Given this list of marker genes PRICKLE2, ZNF497, SYT13 (NCBI Gene Id 57586), ENC1, PLXNA3, C1orf21, RTN1, AMER2, LRRC49, LONRF2, AUTS2 (NCBI Gene Id 26053), AKR1C1, GPRIN1, EMX2, EPB41L1, LETMD1, RBFOX2, RNF182 (ring finger protein 182), NFASC, MAPK8, CXADR, NAP1L5, RALYL, ZBED4, ELAVL4, ELAVL2, ROBO3, ELAVL3, MCF2L, PAK3, NEDD4L, LRRTM4, GDAP1L1, SCRT2, SLC38A1, ANK3, ATCAY, MAP2, TLCD3B, GOLGA7B, KLHL35, MTUS2, TMEM132B, TBC1D2B, GABRG2, SLC8A2, SORCS3, DOCK3, GABRB3, KLHL1, BAALC, C1orf35, CACNB3, SV2A, CD2, PPFIA2, PHACTR3, CELF3, CD24, SEZ6L2, SAMD14, LHFPL4, SBK1, SMIM18, TMEM121B, CELSR3, ATP6V1H, NKAIN1, FGF14, SEPTIN3, POU2F2, KLC1, TES, SLC6A15, CERS6, GREM2, KIF3A, PTPRO, UNC79, PHYHIPL, EBF3, DCLK1, KCNH8, KCNA3, SCN3A, NREP, ADAMTS5, PCDHGC3, ANK2, RBM18, ALDH1L2, DPYSL3, ETFB, SHANK2 (SH3 and multiple ankyrin repeat domains 2), XIST, MAP6, LRFN5, GRIN3A, MARCHF1, RAB3A, CDC42EP3, DUSP4, IQCJ-SCHIP1, MAPK8IP2, UCHL1, NOL4, SLC22A15, SLC16A14, FOXA2, EPB41, USP49, VASH2, NMNAT2, FGF12, PEX5L, PAPPA, BCL11A, JPH4, DNM3, ZNF354A, ACSL6, GPC2 (NCBI Gene Id 2818), B3GALT2, PDE4DIP, ATP1A3, FBLL1, MMP24, SNCG, PHF21B, MYO5A, TRIM36, NSG2, STMN2, TAFA2, NRXN1, CNR1, GNG2, ADARB2, MLLT11, SCARA5, ARRB1, MAPK6, COMMD3-BMI1, NRSN1, NCDN, RELN, BIVM-ERCC5, CDK5R1, ZFHX4, ARFGEF3, PLPPR2, ESRRG, KHDRBS3, CELF4, NRN1, ZNF91, SMPD3, DCX, DMRTA2, ROBO2, SCG3, RNF112, NAPB, ENOX1, CLVS1, CACNG2, LONRF3, CBLN2, DPYSL2, PRKAR2B, STMN4, SAMD5, MIR124-2HG, PLPPR4, NLGN4X, RAB3IP, SRRM4, MCF2, SRCIN1, AKR1C2, C1QL4, PAK5, HIVEP3, MYT1, RUNDC3B, SOX4, LPAR2, PCDH9, KCND2, BRINP2, FNIP2, STMN1, MSANTD3-TMEFF1, SHISA6, NKAIN2, ELOVL4, ST8SIA3, YWHAG, ZSCAN9, STXBP1, GNG3, PTPN5, INA, ENSG00000248540, LZTS1, TMEM169, HOOK1, TERF2IP, BASP1, BZW2, GLRA2, EMX2OS (EMX2 opposite strand/antisense RNA), CPEB3, NCAN, ST6GAL2, CDH22, KMO, SYP, ACTL6B, TMEM196, PGM2L1, UBE2QL1, TENM2, GRIK2, SNAP91, CDK7, CNTN4, GAP43, LPIN1, KIF3C, COMTD1 (NCBI Gene Id 118881), EDIL3, RSBN1, SMAP2, FAXC, TSC1, ATL1, KCNQ3, GRIP1, SEMA3C, OPN3, ACVR2A, LHX1, MIAT, SSBP3, CTNNA2, KCNC1, ANKRD44, OCIAD2, NSG1, ASXL3, RBFOX1, KIF26A, SYT7, FAM117B, RAPGEF5, ZNF124, BEND5, CADPS, SOX11, POU4F1, TSIX, TMEM35A, CCDC184, KIF5C, CHML, ZNF697, SNAP25, RUNX1T1, TAGLN3, RIMS4, TUBB3, TRHDE, NNAT, NHLH2, POU3F1, HAUS1, TUBB2B, PITX2, FBXL16, NOVA1, GRIA2, AKAP6, PLEKHA6, LPGAT1, GPM6A, MAP1B, NXPH4 (neurexophilin 4), CELF5, L1CAM, PAFAH1B3, DOK4, MIR22HG, PCSK2, SLC37A1 (NCBI Gene Id 54020), HUNK, FOXP2, ISLR2 (NCBI Gene Id 57611), SYBU, PBX3, RND3, CRMP1, GPR155, AP1S2, ACVR1B, SLC17A6, DOK6 (docking protein 6), JAKMIP1 (NCBI Gene Id 152789), APLP1, ASIC4, NCAM1, LMTK3, TMEM185B, THSD7A, CLVS2, SH3BP5, FHOD3, OSBPL6, KIF21B, PRSS12, RAB9B, DUSP26, PPP3R1, MAPRE2, MAP7D2, ZFHX3 (NCBI Gene Id 463, zinc finger homeobox 3), PCDHA7, PDE11A, ADA2, GOLGA8B, ZBTB6, BICRAL, RAB3C, CHGA, SLC1A2, here is a description of the gene set: species: Homo sapiens Cell types are named using anatomical and functional mnemonics prefixed by 'm' or'h' to indicate mouse and human respectively: OMTN, oculomotor and trochlear nucleus; Sert, serotonergic; NbM, medial neuroblast; NbDA, neuroblast dopaminergic; DA0-2, dopaminergic neurons; RN, red nucleus; Gaba1-2, GABAergic neurons; mNbL1-2, lateral neuroblasts; NbML1-5, mediolateral neuroblasts; NProg, neuronal progenitor; Prog, progenitor medial floorplate (FPM), lateral floorplate (FPL), midline (M), basal plate (BP); Rgl1-3, radial glia-like cells; Mgl, microglia; Endo, endothelial cells; Peric, pericytes; Epend, ependymal; OPC, oligodendrocyte precursor cells. Human Gene Set: MANNO_MIDBRAIN_NEUROTYPES_HRN from publication La Manno G, Gyllborg D, Codeluppi S, Nishimura K, Salto C, Zeisel A, Borm LE, Stott SRW, Toledo EM, Villaescusa JC, Lönnerberg P, Ryge J, Barker RA, Arenas E, Linnarsson S (PMID 27716510)